The following is a description of a gene set: species: Mus musculus This event has been computationally inferred from an event that has been demonstrated in another species.<p>The inference is based on the homology mapping from PANTHER. Briefly, reactions for which all involved PhysicalEntities (in input, output and catalyst) have a mapped orthologue/paralogue (for complexes at least 75% of components must have a mapping) are inferred to the other species. part of: Regulation of insulin secretion electronically inferred by orthology from the curated human pathway Reactome Pathway: Glucagon-like Peptide-1 (GLP1) regulates insulin secretion, and this is the list of marker genes: Kcng2, Gng10, Gng3, Gnb2, Prkaca, Kcnb1, Gng4, Gcg, Gngt2, Gng7, Gng5, Gng8, Gngt1, Gnb3, Prkacb, Glp1r, Gnb5, Gng11